The following is a description of a gene set: DNAX activation protein of 12kDa (DAP12) is an immunoreceptor tyrosine-based activation motif (ITAM)-bearing adapter molecule that transduces activating signals in natural killer (NK) and myeloid cells. It mediates signalling for multiple cell-surface receptors expressed by these cells, associating with receptor chains through complementary charged transmembrane amino acids that form a salt-bridge in the context of the hydrophobic lipid bilayer. DAP12 homodimers associate with a variety of receptors expressed by macrophages, monocytes and myeloid cells including TREM2, Siglec H and SIRP-beta, as well as activating KIR, LY49 and the NKG2C proteins expressed by NK cells. DAP12 is expressed at the cell surface, with most of the protein lying on the cytoplasmic side of the membrane (Turnbull & Colonna 2007, Tessarz & Cerwenka 2008). part of: Innate Immune System studied in species Homo sapiens Reactome Pathway: DAP12 interactions, and this is the list of marker genes: KLRD1, LCK, RAC1, SHC1, KRAS, SIRPB1, LCP2, KIR2DS4 (killer cell immunoglobulin like receptor, two Ig domains and short cytoplasmic tail 4), HRAS, NRAS, HLA-B, FYN, SIGLEC15, GRAP2, KLRK1, B2M, PIK3CB (NCBI Gene Id 5291), KLRC2, CLEC5A, VAV3, PLCG2, KIR2DS2, PIK3R1, PIK3R2, SIGLEC14, CD300LB, PIK3CA, VAV2, CD300E (NCBI Gene Id 342510), LAT, PLCG1, SYK, TREM2, BTK, KIR2DS5 (NCBI Gene Id 3810), TREM1, HLA-E, GRB2, NCR2, HLA-C, KIR2DS1, SOS1, TYROBP, KIR3DS1, SIGLEC16